Given this list of marker genes CFAP410, UBA1, B3GALT6, ADA (NCBI Gene Id 100), SLC35D1, TRPV4, DNAJC21, DLK1, BGN, SRP54, SUFU, INPPL1, IHH, PCYT1A, MATN3, AIFM1, GPX4, COL11A1, COL2A1 (NCBI Gene Id 444981), COL11A2, RTL1, EFL1, COL10A1, PTCH1, PTCH2, CCN2, DDR2, MEG3, MMP13, SBDS, here is a description of the gene set: species: Homo sapiens Cupped ribs Wide, concave rib end. Human Gene Set: HP_CUPPED_RIBS